The following is a description of a gene set: from publication Manel N, Hogstad B, Wang Y, Levy DE, Unutmaz D, Littman DR (PMID 20829794) studied in species Homo sapiens Genes up-regulated in monocyte-derived dendritic cells infected by: HIV versus HIV and SIV. Dendritic cells (DC) serve a key function in host defense, linking innate detection of microbes to the activation of pathogen-specific adaptive immune responses. Whether there is cell-intrinsic recognition of HIV-1 by host innate pattern-recognition receptors and subsequent coupling to antiviral T cell responses is not yet known. DC are largely resistant to infection with HIV-1, but facilitate infection of co-cultured T-helper cells through a process of trans-enhancement. We show here that, when DC resistance to infection is circumvented, HIV-1 induces DC maturation, an antiviral type I interferon response and activation of T cells. This innate response is dependent on the interaction of newly-synthesized HIV-1 capsid (CA) with cellular cyclophilin A (CypA) and the subsequent activation of the transcription factor IRF3. Because the peptidyl-prolyl isomerase CypA also interacts with CA to promote HIV-1 infectivity, our results suggest that CA conformation has evolved under opposing selective pressures for infectivity versus furtiveness. Thus, a cell intrinsic sensor for HIV-1 exists in DC and mediates an antiviral immune response, but it is not typically engaged due to absence of DC infection. The virulence of HIV-1 may be related to evasion of this response, whose manipulation may be necessary to generate an effective HIV-1 vaccine. Human Gene Set: GSE22589_HIV_VS_HIV_AND_SIV_INFECTED_DC_UP, and this is the list of marker genes: LIMK2, SEMA4G, RBM41, SERPINB2, PARD6B, RNF150, EEF1B2, PIP5K1A, IL6, SCN5A, VTA1, C11orf87, ZNF597, HGF, NISCH, CCR10, GAS8, RALGDS, AMHR2, CEBPZOS, SAMSN1, KCTD9, BCL3, ENPP4, DOP1A, CRHR1, CD80, CDKN2A, PDE4B, USPL1, RNMT, MYO5B, ACD, FXR1, GPR149, BNIP2, RHOT2, TREML1, VWC2L, GADD45A, NANS, PCMTD1, PTPN23, HTRA2, BRPF1, DPYSL5, BAIAP3, GTF2H5, TLR1, ZNF438 (NCBI Gene Id 220929), SLC17A3, RNASET2, CLK3, SET, JUN, CCRL2, ITPKC, C20orf96, NPPC, RAB1A, ATP1A1, SELENOK, ARV1, CSRNP1, USP47, COPG2, ENKUR, CTRL, CRLF3, MYH2, CTLA4, IL1B, HSPA12B, TNFAIP3, TMEM268, KBTBD12, UIMC1, SGSH, PRDM5, GPR84, MAP3K5, NFKBIA, SLFN12L, FNDC9, PGGT1B, PANK2, PLK2, CHIC2, PEG10, MTF2, CDK10, FGD6, DUSP19, EFCAB11, AGFG1, LAPTM5, HMGCR, CACNG8, OAZ1, IL1A, GDF10, DUSP2, COG3, P2RY13, TOP3B, ZFYVE9, PRORP, C11orf86, GRAMD1C, DNASE1, TMOD2 (NCBI Gene Id 29767), SPATA18 (spermatogenesis associated 18), MOB4, TCIRG1, PDE6H, L3HYPDH, POU2AF2, ZNF143, TOGARAM1, MTREX, PIM3, JMJD6, ATP9B, PPP1R12B, KLK4, TFEC, CHRM1, ARMH4, EXO5, KANK1, TRAF6, SLC38A2, ATAD3A, RBM6, RSBN1, RAD54B, TRNAU1AP, PIGA, IFIT1B, CAPG, ARFGAP2, DENND2B, CSRP3 (NCBI Gene Id 8048), PAX3 (paired box 3), OR13J1, KCNMB2, MKI67, CRIPT, SLC15A1, PAH, PEG3, SLC16A14, STXBP3, PKDREJ, MRPS5, GAL3ST2, HIF1A, LTV1, GPR155 (NCBI Gene Id 151556), NEDD8, SCRN2, SOCS5, SHMT1, BDH1, GEM, EGR1 (NCBI Gene Id 1958), ODAD2, GPRC5A, PRDM15, OSM, HES2, SRD5A2, PDAP1, TECTB, TPT1, PAPOLB, PLK3, LRATD2, DOK1, DDA1, TREX1, ERRFI1, CD69, UNC5CL, ASPDH, FSHB, RND1, DEK, CD70, MAN2C1, IL23A, MIR9-2HG, ATP13A5 (ATPase 13A5), TNF, NOP14, CDK17, PRDM1, IRAK2, KLC3